The following is a description of a gene set: Genes up-regulated in secondary APL (acute promyelocytic leukemia) compared to the de novo tumors. Acute promyelocytic leukemia (APL) is a clonal expansion of hematopoietic precursors blocked at the promyelocytic stage. Gene expression profiles of APL cells obtained from 16 patients were compared to eight samples of CD34+-derived normal promyelocytes. Malignant promyelocytes showed widespread changes in transcription in comparison to their normal counterpart and 1020 differentially expressed genes were identified. Discriminating genes include transcriptional regulators (FOS, JUN and HOX genes) and genes involved in cell cycle and DNA repair. The strong upregulation in APL of some transcripts (FLT3, CD33, CD44 and HGF) was also confirmed at protein level. Interestingly, a trend toward a transcriptional repression of genes involved in different DNA repair pathways was found in APL and confirmed by real-time polymerase chain reactor (PCR) in a new set of nine APLs. Our results suggest that both inefficient base excision repair and recombinational repair might play a role in APLs development. To investigate the expression pathways underlying the development of APL occurring as a second malignancy (sAPL), we included in our study eight cases of sAPL. Although both secondary and de novo APL were characterized by a strong homogeneity in expression profiling, we identified a small set of differentially expressed genes that discriminate sAPL from de novo cases. studied in species Homo sapiens from publication Casorelli I, Tenedini E, Tagliafico E, Blasi MF, Giuliani A, Crescenzi M, Pelosi E, Testa U, Peschle C, Mele L, Diverio D, Breccia M, Lo-Coco F, Ferrari S, Bignami M (PMID 16990782) Human Gene Set: CASORELLI_APL_SECONDARY_VS_DE_NOVO_UP, and this is the list of marker genes: KLF4, OTULINL, CNIH4, SLC36A1, TFEC, CSGALNACT1, CLU, TM6SF1, TGFA, LAMC1, HDAC4, NID1, MCTP2, MTARC1, PLAAT3, SLFN12, SLC24A3, FCGRT, FOS, FBN2, ENC1, NAGPA, TMEM35B, EVI2B, TRIM27, HP, ENTPD1, SLC38A6, TMX4, GCA, ANXA5, FZD2, FOSB, CAPN3, DPM3, ARHGEF40, CPQ, MAVS, PTGER2